The following is a description of a gene set: Human Gene Set: GOBP_D_GLUCOSE_IMPORT species: Homo sapiens The directed movement of the hexose monosaccharide D-glucose into a cell or organelle., and this is the list of marker genes: FGF19, SLC2A3, RTN2, AKT2, RHOQ, SLC25A27, SLC2A11, SLC2A5, SIRT6, SLC2A4 (solute carrier family 2 member 4), SLC2A7, IRS1, FGF21, ACACB, RNASEL, APPL1, ADIPOQ, SORBS1, KLF15, HK2, SLC2A9, HNF1A, IRS2, ASPSCR1, MIR143, INSR, PTPN11, ENPP1, MAPK14, OPN3, PLA2G1B, SLC2A14 (solute carrier family 2 member 14), SGCB, GSK3A, INS, OSTN, IGF1, LEP (NCBI Gene Id 3952), MIR223, SESN2, DHRS7C, ITLN1, TRARG1, CLTCL1, DRD1, MIR107, PTH, OSBPL8, TERT, SLC2A2, PID1, PRKCI, AKT1, SLC27A1, ERFE, MEF2A, PEA15, PIK3R1, APPL2, SLC2A1 (NCBI Gene Id 6513), RAP1A, POU4F2, C1QTNF12, TNF, ZDHHC7, GRB10, CD2AP, ARPP19, RAB4B, CERS1, SORT1, SLC27A4, CAPN10, NFE2L2, MIR103A1, TSC1, PRKAG2, GPC3 (NCBI Gene Id 6394), CREBL2, SLC1A2, OCLN, SELENOS, STXBP3